Given this list of marker genes Terf2, H4c2, H4c3 (H4 clustered histone 3), H2ac4, H4c6 (H4 clustered histone 6), H2ac11, H2ac13, H2ac22, H2ac23, H4c8, H4c11, H4c17 (H4 clustered histone 17), H2bc22, H2bc7, H2ac6, Acd, H2bc3, H2bc11, H4c1, H2az2, H2ac15, H2ac10, H4c14, H2ac8, H4c12, H2bc15, H4c4, Ogg1, H2bc8, H2ax, H2bc12, H2bc9, Terf1, H2ac1, H2ac12, H2ac24, H2bc27, H2ac19, H2bc13, H4c18, H4c9 (H4 clustered histone 9), H2ac20, H2ac7, H2bc1, here is a description of the gene set: part of: Depurination Reactome Pathway: Recognition and association of DNA glycosylase with site containing an affected purine This event has been computationally inferred from an event that has been demonstrated in another species.<p>The inference is based on the homology mapping from PANTHER. Briefly, reactions for which all involved PhysicalEntities (in input, output and catalyst) have a mapped orthologue/paralogue (for complexes at least 75% of components must have a mapping) are inferred to the other species. species: Mus musculus electronically inferred by orthology from the curated human pathway